Given this list of marker genes Ube2n, Prex2, Nlk, Ubr1, Tsc2, Kptn (kaptin), Prkaa2, Rps6kb1, Atxn3, Otud7b, Hif1a, Kics2, Peli1, Deptor, Pten, Sesn3, Vhl, Minar1, Nprl2, Spaar, Epm2a, Sesn1, Flcn, Itfg2 (NCBI Gene Id 68200), Pdcd6, Bmt2, Gsk3a, Gsk3b, Rnf167, Szt2, Cryba1, Sar1b, Mapkapk5, Ddit4, Castor2, Prkaca, Sar1a, Npc1, Stk11, Ubr2, Tmem127, Alg13, Depdc5, Prkacb (NCBI Gene Id 18749), Fnip1, Akt1s1, Tsc1, Ube2d1, Endog, Sh3bp4, Atm, Ywhaz, Mapk3, Mtm1, Bmal1, Sesn2, Tnfaip8l1, Rps6ka1, Tbc1d7, Castor1 (NCBI Gene Id 71962), Sirt1, Ube3a, Ube2w, Usp7, Prex1, Nprl3, Rnf152, Ywhag, Tbk1, Prkaa1, here is a description of the gene set: Mouse Gene Set: GOBP_NEGATIVE_REGULATION_OF_TOR_SIGNALING Any process that stops, prevents, or reduces the frequency, rate or extent of TOR signaling. species: Mus musculus